Given this list of marker genes HOXB3, GPC1-AS1, EGFR, DLX5, ETV3, FLT1, GCM1, ENDOU, PAPPA2, HMGB3, MAGEA10, ACVR2B, PDPN, HMGB3P30, GALE (NCBI Gene Id 2582), PLXNA3, EMX1, INSL4, TLX2, ADAM12, CPT1B (NCBI Gene Id 150414), VGLL1, KISS1, CYP19A1, ATF6B, PSG6, SERPINB2, PHLDA2, GJA5, MSX2, here is a description of the gene set: Human Gene Set: SU_PLACENTA Genes up-regulated specifically in human placenta. species: Homo sapiens from publication Su AI, Cooke MP, Ching KA, Hakak Y, Walker JR, Wiltshire T, Orth AP, Vega RG, Sapinoso LM, Moqrich A, Patapoutian A, Hampton GM, Schultz PG, Hogenesch JB (PMID 11904358) High-throughput gene expression profiling has become an important tool for investigating transcriptional activity in a variety of biological samples. To date, the vast majority of these experiments have focused on specific biological processes and perturbations. Here, we have generated and analyzed gene expression from a set of samples spanning a broad range of biological conditions. Specifically, we profiled gene expression from 91 human and mouse samples across a diverse array of tissues, organs, and cell lines. Because these samples predominantly come from the normal physiological state in the human and mouse, this dataset represents a preliminary, but substantial, description of the normal mammalian transcriptome. We have used this dataset to illustrate methods of mining these data, and to reveal insights into molecular and physiological gene function, mechanisms of transcriptional regulation, disease etiology, and comparative genomics. Finally, to allow the scientific community to use this resource, we have built a free and publicly accessible website (http://expression.gnf.org) that integrates data visualization and curation of current gene annotations.